The following is a description of a gene set: species: Homo sapiens Human Gene Set: PTTG1_TARGET_GENES Genes containing one or more binding sites for (PTTG1) in their promoter regions (TSS -1000,+100 bp) as identified by GTRD version 20.06 ChIP-seq harmonization. from publication Yevshin I, Sharipov R, Kolmykov S, Kondrakhin Y, Kolpakov F (PMID 30445619), and this is the list of marker genes: WBP1L, LRRC61, PCSK6, SUMO2, GNG4, BCAT1, RBBP4, NIFKP7, NTPCR (nucleoside-triphosphatase, cancer-related), CDCA3, IKBKB-DT, CMTM3, ZFYVE1, SYF2, VMP1, UFL1 (UFM1 specific ligase 1), ZNF8, NAGLU, SEC24C, TULP2, TIMM50, UBA5, MAK16, ZBTB8OS, ANKRD65, DHRSX, LSM10, TRMT12, RNU6-194P, STXBP5-AS1, EOGT, VDAC2, GTF2IRD1, MIR7-3HG, SNHG20, ZNF8-ERVK3-1, PPP4R1L, ZSCAN31, NOSIP, ASAP3, OPLAH, LINC02252, LINC03016, CARD8, PCAT14, LINC03108, SUGCT-AS1 (NCBI Gene Id 101928716), SEC14L1, LINC01732 (long intergenic non-protein coding RNA 1732), MYO3B-AS1, UCA1, PSME2P3, ENSG00000221040, CRYBG2, AFF4, AP2S1, CLPX (caseinolytic mitochondrial matrix peptidase chaperone subunit X), CCDC136, ENSG00000206898, DENR, ACBD5, SAMD9L, CPNE2, CARD8-AS1 (CARD8 antisense RNA 1), LINC02577, LINC00824, DDX3ILA1, TMEM14B, NUPR1 (nuclear protein 1, transcriptional regulator), ENSG00000237346, NBPF11, TRIB3, SLX4IP, STRIP1, MIR7-3, ENSG00000232124, ERI1, LEPROTL1, TMEM161B, LINC01088, MKKS, RIN3, MIR4766, DNALI1, ATF7IP2